Given this list of marker genes IL1B, VTCN1, BTNL2, CD86, ANXA1, SASH3, PDE4B, RPS3, MAP3K7, CLEC7A, STAT5A (signal transducer and activator of transcription 5A), PTPRC, ABL1, CD28, DEFB124, TRAF6, PRKD2, PLCG2, CCR2, STAT5B, IL1A, CD80, PDE4D, GLMN, IRF4 (NCBI Gene Id 4592), STOML2, CARD11, RIPK2, PRKCQ, MALT1, PNP, CD83, RUNX1, TRAF2, SPTBN1, CD3E, CD4, here is a description of the gene set: Human Gene Set: GOBP_POSITIVE_REGULATION_OF_INTERLEUKIN_2_PRODUCTION species: Homo sapiens Any process that activates or increases the frequency, rate, or extent of interleukin-2 production.